Given this list of marker genes Mir7080, Gm5190, 9930014A18Rik, Arhgef10l, Adcy6, Ext1, Smarca2, Gm9729, Plec, Grid2ip, Gm13333, Oser1, Syf2, Pttg1ip, Gid4, Cd3g, Gm13179, Mrm1, Pick1, Gm829, Tex261, Ninj2 (ninjurin 2), Baalc, Unc93b1, Filip1, Mamstr, Gm11827 (predicted gene 11827), Prnp, Sspo, Chst3, Gm13337, H2bc6, Ier5 (immediate early response 5), Cenpm, Abat, Ano6, Gm23734, Hnrnpa1, Mir669m-2, H2ac8, Ubd, Stra6, Gm4189, Srsf7, 2700033N17Rik, Bcl2l14, Ptges3, Folr1, Fgd6, Gm4865, Apc, Rnf146, Dctn6, Sv2c, Mylip (myosin regulatory light chain interacting protein), Gm11643, Cd3d, Igfbp4, Pdia3, Foxp4, Nupr1 (NCBI Gene Id 80556), Asb1, Rab13, Slc29a1, Gm13836, Slc22a16, Icam2, Dhh, Fcnb, Vgf, 2010109A12Rik, Snrpd3, A730036I17Rik, Fam229a, Zfp345, Gm6101, 5730420D15Rik (RIKEN cDNA 5730420D15 gene), Unc13a, Ank3, Chchd3, Gls, Prn, Dmrta1, Camk2a, Or2w3, Phaf1, Snord3a, Tcf4, Phox2a, Pak1, 1700042O10Rik, Hdnr, Taldo1, Tmeff2, Rimbp2, Mdm1, Gm26703, Tgoln1, A330041J22Rik, Tmem164, Eif3f, Apc2, Vmp1, Mideas, Pacc1, Gm13754, Scyl3, Actr1b, Pax1dt, Snhg17, Slc38a2, Wnt5a, Saal1, Lgmn, Prcd, Polr2a, Mtmr11, Paqr5, Wdpcp, Cstb, H3f3b, Gm9929, Saxo2, Tspan15, Gfm2 (G elongation factor, mitochondrial 2), Gabarap, Gm35202, Zfand5, Gm8606 (NCBI Gene Id 667394), Gm12093, Zfas1, Gm15577, Pde2a, Paip1, Bltp1, 4930592C13Rik, Malat1, Car6, Golm2 (NCBI Gene Id 319996), Snord13, Pde10a, Gm11381, Nyap1, Ppp4r1, A4galt, Atr, H4c4 (NCBI Gene Id 319156), Ubap2l, Cryba4, Fam149a, Elavl4, Krt86, Gm9996, Tdrd5, Per3, Chrna9, 4930449E01Rik, Or4x11, Gm11585, Clip3, Slc18a2 (solute carrier family 18 (vesicular monoamine), member 2), Cdon, Pcsk6, Hk1, Sparcl1, Rapgef2, Gm29543, Tex14, Lsp1, Mir669m-1, Pnkd, Fasn, B3gnt8, Slc6a15, A230083G16Rik, Gm22630, Cntfr, Sntg1, Eif2b5, Ssc5d, Akr1b10, Gm12094, Mir8112, Gnb1, Zfp948, Vegfa (vascular endothelial growth factor A), Gm13431 (NCBI Gene Id 100504593), Gm12216, Relt, Tshz2, Kcnip4, Csgalnact2, Socs2, Gm23887, Nfix, Pla2g3, 1600020E01Rik (RIKEN cDNA 1600020E01 gene), Ufsp2, Gm33973, Spsb3, Mest, Zdhhc8, Atf6, Gm26075, Ccdc50, Hoxc4, Gm25878, Pbx1, Itgb1bp2, Ipo8, Cert1, Csrnp2, Sap30, Celf6, Pax6 (NCBI Gene Id 18508), Znfx1, Daglb, 5930403N24Rik, Psmd5, Adgrd1, Atf7, Cbx5, Prim2, Pde4b, Ablim1, Tyro3, Gm3828, A330023F24Rik, Timeless, Ctnnb1, Atg16l2, Atp8b2, Preb, Bscl2, Gucd1, Taf13, Otx1 (orthodenticle homeobox 1), Mir5620, Marcks, Emid1, Nat10, Sec61a1, Calm1, Klhdc2, H2ac15, Gm6313 (predicted gene 6313), Myo18b, Gm11398, Uchl5, Chmp3, Nubp2, Insyn2b, Gipc2, Camk2b, Gtf3c6, Polk, Hsd17b14, 1110004F10Rik, Ddrgk1, Gm11694, Rdm1, Thra, Tti2, Nynrin, Gadd45b, Catsper2, Tmem19, Lrrc8d, Ccni, Gkn3, Mob1a, Tmcc3, Zranb2, Mbnl1, Lmna, Timm29, Dgat1, Rabgap1l, Ak5, Atp6v1a, Etv1, Gm42133, Ptms (NCBI Gene Id 69202), Spty2d1, Ppfia2, Ywhaz, Septin9, Pcdh17, Eeig2, Ralgps1, Cfap96, Fgfr4, A630023P12Rik, Lockd, Rnu7, Gm12676, Ddit3 (NCBI Gene Id 13198), Tgfb2, 1700003G18Rik, Aasdh, Mia2, Prmt9, Myt1l, H2bc18, Fmo3, Gm4953, Zbtb7c (zinc finger and BTB domain containing 7C), 1700001G17Rik, Armc6, Batf, Gria2 (NCBI Gene Id 14800), 9830144P21Rik, Gm35409, Cabp1, Rpl27a-ps1, Tmprss9, Nt5c, Otos, Grcc10, Junb, Scml4, Rps27, Dock2, Tcte2, 4931414P19Rik, Capn5, Mexis, Mir5129, Atpaf2, Manba, Ccdc12, Tex10, Spata20, Psip1, Ttc39d, Cacng3, Gm11680, G630016G05Rik (NCBI Gene Id 654793), Phldb1, Mgat1, Hsd3b3, Efr3a, Adgb, Prima1, Pcbp1, 5730460C07Rik, Nkx2-6, Zfp180, Gm16364, Sugp2, Sh3bgrl2, here is a description of the gene set: from publication Yevshin I, Sharipov R, Kolmykov S, Kondrakhin Y, Kolpakov F (PMID 30445619) species: Mus musculus Mouse Gene Set: NACC1_TARGET_GENES Genes containing one or more binding sites for (Nacc1) in their promoter regions (TSS -1000,+100 bp) as identified by GTRD version 20.06 ChIP-seq harmonization.